The following is a description of a gene set: species: Homo sapiens The aggregation, arrangement and bonding together of a proton-transporting two-sector ATPase complex, a large protein complex that catalyzes the synthesis or hydrolysis of ATP by a rotational mechanism, coupled to the transport of protons across a membrane. Human Gene Set: GOBP_PROTON_TRANSPORTING_TWO_SECTOR_ATPASE_COMPLEX_ASSEMBLY, and this is the list of marker genes: ATPAF2, CCDC115, ATP6V1B1, OXA1L, TMEM70, TMEM9, VMA21, ATPAF1, TMEM199, ATP5F1D, ALDOB (NCBI Gene Id 229), TM9SF4 (transmembrane 9 superfamily member 4), TMEM242, ATP23, PIP4P1, FMC1 (NCBI Gene Id 154791)